Given this list of marker genes Il21, Cd226, Cd160, H2-T23, Gimap3, H2-M3, Clnk, Gimap5, here is a description of the gene set: studied in species Mus musculus Any process that activates or increases the frequency, rate, or extent of natural killer cell cytokine production. Mouse Gene Set: GOBP_POSITIVE_REGULATION_OF_NATURAL_KILLER_CELL_CYTOKINE_PRODUCTION